Given this list of marker genes Ap5z1, Ptgis, Adamts20 (NCBI Gene Id 277181), Cd207, Cripto, Slc23a2, Ggnbp1, Aff4, Maml3, Fcrla, 1700025G04Rik, Stx16, T, Slc7a5, Msi2, Zfr, Eif5, Tmed10, Ctxn1, Tpst1, Ctnnd2, Nkrf, Smim10l1, Csn3, Rnf111, Bdp1, Adgra2, Rexo2, Scgb2b17, Adcy3, Ccnj, Csmd1, Il1rl1, Srsf6, Ralyl, Lgr4, Cdh2 (NCBI Gene Id 12558), Srpk2, Ro60, Mttp, Marchf4, Pknox1, Ppp3ca, Bnc1, Dpy19l2, Hoxc4, Cenpk, Hdac9, Mtm1, Lrrc40, Med13l, Gabrg2, Zfp704, Eif2b2, Zc3h12a, Ufc1, Chtop, Scgb2b7, Ecm2, Ston2, Vmn1r132, Hic2, Plekha7, Cul4a, Adrb1, Suz12, Hmgn3, Pqbp1, Ccdc141, Fzd2, Btg3, Tgfbr1, Cnot8, Apc, Ing4, Grem2, Scgb2b12 (NCBI Gene Id 668379), Nipbl, Sfrp1, Ctr9, Gdnf, Tor1aip1, Tle3, Mtdh, Ube2b, Eef1b2, Jakmip3, Cep170, Nt5dc3, Stag1, Alkal1, Marveld3 (NCBI Gene Id 73608, MARVEL (membrane-associating) domain containing 3), Paip2, Lonrf1, Lhfpl3, Znrf3, Mdk, Klhl24, Nsd3, Taf7, Ipo9 (NCBI Gene Id 98447), Ube2d2a, Pi15, Pde7a, Gls, Me1, Plpp3, Cltc, Smc6, Clock, Rnf38, Ccl25, Unc80, Mef2a, Akap6, Prdm6, Tmem170b, Mcur1, Nufip2, Ccnyl1, Gsn, Scgb2b20, Cep43, Cnmd (chondromodulin), Stxbp1, Pcdh8, Map4k5, Zbtb16, Slc12a6, Serp1, Tprg1l, Slk, Rnf11, Vdr, Nog, Stc1, Cdr2, Il6st, Sirt1, Dclre1c, Grik2, Lrrc3b, Abtb3, Grp, Zfp36l1, Ifit1bl2 (interferon induced protein with tetratricopeptide repeats 1B like 2), Tm9sf3, Lcor, Gnrhr, Katnal1, Cdh20, Cep97, Gnai3, Dip2a, Mxi1, Scgb1b27, Trpc5, Rab9b, Map4, Aloxe3, Scgb2b19, Creb1, Hnrnph2, Scgb2b15, Cdk19, Higd2a, Mfap3l, Ttll7, Semp2l2a, Arhgef26, Ube2k, Arl8b, Aoc3, Fbxo3, Ube2d2b, Naa15 (NCBI Gene Id 74838), Onecut2 (one cut domain, family member 2), here is a description of the gene set: Mouse Gene Set: MIR_6415 Genes predicted to be targets of miRBase v22 microRNA mmu_miR_6415 in miRDB v6.0 with MirTarget v4 prediction scores > 80 (high confidence targets). species: Mus musculus from publication Chen Y, Wang X (PMID 31504780)